The following is a description of a gene set: Motor regression Loss of previously achieved motor skills, as manifested by loss of developmental motor milestones. species: Homo sapiens Human Gene Set: HP_MOTOR_REGRESSION, and this is the list of marker genes: NFU1, COX15, DPH5, HSD17B4, TRAPPC6B, CLN8, NDUFA6, SELENOI, LRPPRC, SNAPC4 (small nuclear RNA activating complex polypeptide 4), STN1, EPRS1, GLB1, POLR3K (RNA polymerase III subunit K), POLR3GL, ADH5, NGLY1